The following is a description of a gene set: species: Mus musculus Cytokines mediate cell-cell communication in the immune system and represent important therapeutic targets. A myriad of studies have highlighted their central role in immune function, yet we lack a global view of the cellular responses of each immune cell type to each cytokine. To address this gap, the authors created the Immune Dictionary, a compendium of single-cell transcriptomic profiles of more than 17 immune cell types in response to each of 86 cytokines (>1,400 cytokine-cell type combinations) in mouse lymph nodes in vivo. A cytokine-centric view of the dictionary revealed that most cytokines induce highly cell-type-specific responses. For example, the inflammatory cytokine interleukin-1β induces distinct gene programmes in almost every cell type. A cell-type-centric view of the dictionary identified more than 66 cytokine-driven cellular polarization states across immune cell types, including previously uncharacterized states such as an interleukin-18-induced polyfunctional natural killer cell state. Mouse Gene Set: CUI_TREG_IFNE_RESPONSE_DN Genes negatively differentially expressed in cell type: Treg upon treatment with cytokine: IFN-ε in mouse lymph nodes in vivo. from publication Cui A, Huang T, Li S, Ma A, Pérez JL, Sander C, Keskin DB, Wu CJ, Fraenkel E, Hacohen N (PMID 38057668), and this is the list of marker genes: Uba52, Klf6, Jun, Cd83, Elof1, Ifi27, Dusp1, Hspa1a, Rgs2, Hspa1b, Fos